Given this list of marker genes FOXG1, ROBO3 (roundabout guidance receptor 3), APP, ROBO2, ROBO1, here is a description of the gene set: Human Gene Set: GOBP_AXON_MIDLINE_CHOICE_POINT_RECOGNITION species: Homo sapiens The recognition of molecules at the central nervous system midline choice point by an axon growth cone; this choice point determines whether the growth cone will cross the midline.